Given this list of marker genes KIFBP, SLC26A2, MADD, GABBR1, UBAP2L (ubiquitin associated protein 2 like), here is a description of the gene set: An increased degree of femoral version, which is defined as the angular difference between axis of femoral neck and transcondylar axis of the knee. Thus, femoral anteversion is an inward twisting of the femur that causes the knees and feet to turn inward. species: Homo sapiens Increased femoral anteversion Human Gene Set: HP_INCREASED_FEMORAL_ANTEVERSION